Given this list of marker genes Pkd2, Stat1, Fmn1, Lgr4, Hes1, Sox9, Gdnf, Smo, Wt1 (NCBI Gene Id 319408, WT1 transcription factor), Pax8, Hes5, Wnt9b, Pkd1, Kif26b, Sall1, Six2, Lif, Cited1, Lhx1, Pax2, Sox8, Ctnnb1, Bmp4, Grem1, Wnt4, here is a description of the gene set: studied in species Mus musculus The process in which the anatomical structures of the metanephric nephron are generated and organized. A metanephric nephron is the functional unit of the metanephros. Mouse Gene Set: GOBP_METANEPHRIC_NEPHRON_MORPHOGENESIS